Given this list of marker genes Rcc1, Sult1a1, Cd34, Gns, Glycam1, Smad4, here is a description of the gene set: Binding to sulfate, SO4(2-), a negatively charged small molecule. studied in species Mus musculus Mouse Gene Set: GOMF_SULFATE_BINDING